Given this list of marker genes NRXN1, FOXP2 (forkhead box P2), CCNB1, POLR3H, GGN, PLK4, CDC45, PHF12, ID4, ARHGAP5, SCUBE3, GNAI2, PIGT, RNF213, PPM1L, SFN, PRADC1 (protease associated domain containing 1), SLC26A9, LHX1, TMPRSS11F, TTC9C, SOX4, RLN2, PPP2R2A, MED8, HOXA6, LMO1, UFD1, PLXNC1, SH3RF1 (NCBI Gene Id 57630), TMED10, CYP21A2, ALDH1A2, CLDN16, RFX5, MACC1, PHB2, DAXX, MYH14, MAGT1, JUN, NR3C2, PCNA, ARHGAP33, ARL17A, PMEL, CYTH2, YBX1, EXOC3L1, PAGR1, DHX57, IL6ST, NXT2, FOXN3, RBMS1, KPNB1, TREX2, ZFY, HNRNPLL, RCC2, UQCRH, CPNE1, BCL6, PPM1E, LINC00173, USP2, TSPYL2, DMD, GOLPH3L, MKNK2, SPC25, SLC22A17, ARL4C, FAM86C1P, SMURF2, MTMR4, LINC01312, RHOB, HLA-DQA1, STARD4, CFAP36, CDK2, SHC1, H2AC25, TMTC1, EDA, ADCY8, CYRIA, TERF1, TUBA1A, TSPOAP1, PRCP, POLR3GL, LDB2, IL4, NCDN, RLN1, HSD11B1, BRWD3, ARVCF, CLDN14 (claudin 14), UBXN11, GRIA3, HHEX, E2F4, SP2, OTOR, TSPAN33, ING4 (NCBI Gene Id 51147), H2BC26, DNM2, CCT7, ANGPTL1, RAB6A, TPGS2, EMG1, EIF1, TESK2, SZT2, PDS5B, SLITRK1, FIP1L1, CKS1B, RBL2, ATOH1, EEF2KMT, MECOM, GAN, NUCKS1, AKR1B1, METTL26, MFSD2A, PPP2R5D, APH1A, ZNRF2, LRRC41, CHD2, TBX19, KDM3A, H3-3B, MORN2, PPM1B, DAAM1, VGLL4, DDIAS, CACNG8, CTNND1, EIF2AK3, RLIM, here is a description of the gene set: Genes having at least one occurrence of the highly conserved motif M124 CCAWYNNGAAR in the regions spanning 4 kb centered on their transcription starting sites. The motif does not match any known transcription factor binding site. Human Gene Set: CCAWYNNGAAR_UNKNOWN Comprehensive identification of all functional elements encoded in the human genome is a fundamental need in biomedical research. Here, we present a comparative analysis of the human, mouse, rat and dog genomes to create a systematic catalogue of common regulatory motifs in promoters and 3' untranslated regions (3' UTRs). The promoter analysis yields 174 candidate motifs, including most previously known transcription-factor binding sites and 105 new motifs. The 3'-UTR analysis yields 106 motifs likely to be involved in post-transcriptional regulation. Nearly one-half are associated with microRNAs (miRNAs), leading to the discovery of many new miRNA genes and their likely target genes. Our results suggest that previous estimates of the number of human miRNA genes were low, and that miRNAs regulate at least 20% of human genes. The overall results provide a systematic view of gene regulation in the human, which will be refined as additional mammalian genomes become available. species: Homo sapiens from publication Xie X, Lu J, Kulbokas EJ, Golub TR, Mootha V, Lindblad-Toh K, Lander ES, Kellis M (PMID 15735639)